The following is a description of a gene set: Human Gene Set: GOBP_RESPONSE_TO_NITROSATIVE_STRESS Any process that results in a change in state or activity of a cell or an organism (in terms of movement, secretion, enzyme production, gene expression, etc.) as a result of a nitrosative stress stimulus. Nitrosative stress is a state often resulting from exposure to high levels of nitric oxide (NO) or the highly reactive oxidant peroxynitrite, which is produced following interaction of NO with superoxide anions. species: Homo sapiens, and this is the list of marker genes: ADH5, GCLC, ATG5, PARK7, STOX1, GCLM, DUSP6, ATM, DNAJA1, DDIT3